The following is a description of a gene set: Human Gene Set: MIR6841_3P Genes predicted to be targets of miRBase v22 microRNA hsa-miR-6841-3p in miRDB v6.0 with MirTarget v4 prediction scores > 80 (high confidence targets). species: Homo sapiens from publication Chen Y, Wang X (PMID 31504780), and this is the list of marker genes: TRIP12, ICMT, SLC28A3, SPATA13, DDX60L, CDKL2, CALU, PAN3, CCSAP, FYTTD1 (forty-two-three domain containing 1), FAM120C, HS6ST2, DOT1L (NCBI Gene Id 84444), PTPRE, DOCK3, ESCO1, EPHA4, KITLG, BAZ2B, TLL1, NUDT10, SGIP1, DCHS2, LCA5 (NCBI Gene Id 30828), PFKFB2, EIF4G2, GPN1, SYT9, C6, SV2B, AKT3, STIMATE, IL1RL1, CMPK2, MTRF1L, TXNL4A, SPTY2D1, GADD45A, PRDM6, ACO2, GRID2 (glutamate ionotropic receptor delta type subunit 2), SLCO1B3, MIER3, RAB1B, NCR2, ODF4, HOXC4, UGT3A1, DNAJC14, FILIP1L, PRRG4, HNRNPA2B1, MYBPC1, MTARC2